Given this list of marker genes SERPING1, DNAAF1, SFTPC, MIR140, ODAD4, ABCA3, ODAD1, DNAAF11, CCDC40, FOXJ1, CSF2RB, FAM13A, SLC5A7, PRIM1, CFTR, RTEL1, STN1, COL13A1, STK36, DNAJB13, SLC25A46, AGRN, PARN, CFAP298, NME5, BTK, CFAP221, SNAP25, DNAAF3, TERC, RSPH3 (NCBI Gene Id 83861), SLC52A3, EXOSC3, SCO2, LAMB3, EXOSC9, IGHMBP2, TTC12, CSF2RA (colony stimulating factor 2 receptor subunit alpha), DNAH1 (dynein axonemal heavy chain 1), DNAH5, CFAP74, FLNA, HLA-DRB1, CCNO, RSPH4A, TSPYL1, DNAAF2, SCNN1G, DNAAF6, SERPINA1, NFIX, DNAL1, NKX2-1, VAMP1, SCARF2, OFD1, CRLF1, DNAAF4 (NCBI Gene Id 1867), RPGR (NCBI Gene Id 6110), HLA-DQA1, DNAH11, LAMA3, SLC25A1, MYO9A, D2HGDH, DPP9, CCDC39, ZMYND10, AGR2, NFASC, RYR1, CHAT, SOX9, RSPH9, DRC1, GBA1, ODAD2, HYDIN, LRRC56, GTPBP3, SLC18A3, TERT, DST, SCNN1B, NEK10, GNB1, NOS1, EXOSC8, GNPTAB, TRPV4, SCN4A (sodium voltage-gated channel alpha subunit 4), SPAG1, AGTPBP1, DSP (desmoplakin), VRK1, NME8, ATP8B1, SPEF2, MUC5B, HLA-DQB1, LYRM4, SFTPA2 (surfactant protein A2), POT1, KIF22, DNAI1, JAG1, RSPH1, FCGR3A, CTSK, ODAD3, VPS33A, LAMC2, MAP3K7, PLP1, ATP11A, PAX8, GAS2L2, SFTPA1 (surfactant protein A1), DNAAF5, DNAH9, DNAI2, COQ2 (coenzyme Q2, polyprenyltransferase), SCNN1A, CFAP300, MID1, SYT2 (synaptotagmin 2), CACNA1C, SLC18A2 (solute carrier family 18 member A2), MCIDAS, here is a description of the gene set: Abnormal breath sound Human Gene Set: HP_ABNORMAL_BREATH_SOUND studied in species Homo sapiens An anomalous (adventitious) sound produced by the breathing process.